The following is a description of a gene set: Genes with known mitosis function that were down-regulated in MEF cells (embryonic fibroblast) upon knockout of LIN9. from publication Reichert N, Wurster S, Ulrich T, Schmitt K, Hauser S, Probst L, Götz R, Ceteci F, Moll R, Rapp U, Gaubatz S (PMID 20404087) species: Mus musculus Mouse Gene Set: REICHERT_MITOSIS_LIN9_TARGETS The retinoblastoma tumor suppressor protein (pRB) and related p107 and p130 pocket proteins function together with the E2F transcription factors to repress gene expression during the cell cycle and development. Recent biochemical studies have identified the multisubunit DREAM pocket protein complexes in Drosophila melanogaster and Caenorhabditis elegans in regulating developmental gene repression. Although a conserved DREAM complex has also been identified in mammalian cells, its physiological function in vivo has not been determined. Here we addressed this question by targeting Lin9, a conserved core subunit of DREAM. We found that LIN9 is essential for early embryonic development and for viability of adult mice. Loss of Lin9 abolishes proliferation and leads to multiple defects in mitosis and cytokinesis because of its requirement for the expression of a large set of mitotic genes, such as Plk1, Aurora A, and Kif20a. While Lin9 heterozygous mice are healthy and normal, they are more susceptible to lung tumorigenesis induced by oncogenic c-Raf than wild-type mice. Together these experiments provide the first direct genetic evidence for the role of LIN9 in development and mitotic gene regulation and they suggest that it may function as a haploinsufficient tumor suppressor., and this is the list of marker genes: Cep55, Cdca2, Ncapd2, Myo6, Nusap1, Ccnb1, Anapc1, Kif20a, Cdk11b, Knl1, Vcpip1, Kif23, Fbxo5, Kif2c, Lmln, Plk1, Top2a, Cald1, Aspm, Aurka, Hmgb2, Mki67, Cenpf, Cenpe, Ccnf, Hmmr, Cenpa